The following is a description of a gene set: species: Mus musculus This event has been computationally inferred from an event that has been demonstrated in another species.<p>The inference is based on the homology mapping from PANTHER. Briefly, reactions for which all involved PhysicalEntities (in input, output and catalyst) have a mapped orthologue/paralogue (for complexes at least 75% of components must have a mapping) are inferred to the other species. electronically inferred by orthology from the curated human pathway Reactome Pathway: Peptide chain elongation part of: Eukaryotic Translation Elongation, and this is the list of marker genes: Eef2